The following is a description of a gene set: species: Mus musculus from publication Yevshin I, Sharipov R, Kolmykov S, Kondrakhin Y, Kolpakov F (PMID 30445619) Genes containing one or more binding sites for (Tgif2) in their promoter regions (TSS -1000,+100 bp) as identified by GTRD version 20.06 ChIP-seq harmonization. Mouse Gene Set: TGIF2_TARGET_GENES, and this is the list of marker genes: Gm11346 (NCBI Gene Id 76024), Cyb5d2, Phf19, Pierce2, Atosa, Pcyt1a, Ankrd35, Maf, Dhx15, Npdc1, Hectd3 (NCBI Gene Id 76608), Tbl3, Tsc1, Urgcp, Slc30a1, Slk, Mbd6, Ltn1, Gpr137c, Faf1, Scfd2, Zfp68, 4930473A02Rik, Kin, Uvrag, Rbm39, Asb1, D030028A08Rik, Gm16894 (NCBI Gene Id 100047133), Pcbp4, Gm38250, Ms4a13, Otub2, Pde4dip, 1700057H15Rik, Nup58, Poc5, Wdr26, Mylpf, Kti12, Pfkfb2, Prr11, Polr2l (NCBI Gene Id 66491), Actr1b, Mfap3l, Glis1, Mrps26, Nol4l, Ccz1, 4930404H24Rik, 6430590A07Rik (RIKEN cDNA 6430590A07 gene), Grm2, Ppp1r3e, Pusl1, Smim5, Smdt1, Ap1g2, Ltv1, Slc25a44, Il1r2, Shisa7, Sptlc1, 1700112J16Rik, 9530036O11Rik, Per1, Kmt2c, Dffa, Urb2, Dynlrb2, Zhx3, Acap3, Mxd4, Ccpg1, Gm6283, Rnf214, Mfap1a, Plcl1, Edrf1, Zfp408, Ankzf1, Zzef1, Cyb5b, Pank1, Yif1a, Wdr76, 1700056E22Rik, Cyb5r4, 9230114K14Rik, Pcx, Fbxo8, Atp6v1h, Myadml2, Znhit6, Abhd18, Zhx1, Atp5f1c, Adamts3, Fem1a, BC025920, Tnnt1, Herpud1, Ranbp6, Per2, Mks1 (MKS transition zone complex subunit 1), Gpr158, Zc3h7a, Naa25, Fn3k, Taf5l (TATA-box binding protein associated factor 5 like), Bicdl1, Tbc1d2, Arl6ip5, Ckap2l, Atp6v0d1, 6430548M08Rik, Ciao3, Pfn2, Txndc16, Slc25a16, Scrn1, Sugp2, Rad51ap1, Adgb (NCBI Gene Id 215772), Apmap, Tspan4, 4930526L06Rik, Arhgap1, Mars1, Rundc3b, Mfsd8, Slc35e4, Atosb, Hykk (NCBI Gene Id 235386), Cirbp, 5730522E02Rik, D6Wsu163e, Ska2, Nt5m, Trappc10, Armc6, Gm4152, Pnpo, Atg9a, Urod, Cep44, Wiz, Gm10766, Snx32, Abcg2, Ankrd45, Apobec3, Pvr, Stard7, Dusp10